The following is a description of a gene set: species: Mus musculus The chemical reactions and pathways resulting in the breakdown of a glycoprotein, a protein that contains covalently bound glycose (i.e. monosaccharide) residues; the glycose occurs most commonly as oligosaccharide or fairly small polysaccharide but occasionally as monosaccharide. Mouse Gene Set: GOBP_GLYCOPROTEIN_CATABOLIC_PROCESS, and this is the list of marker genes: Fbxo17, Ctsl, Sgsh, Stt3b, Edem1, Hgsnat, Gusb, Glb1, Hyal4, Hpse, Ngly1, Fbxo2, Nccrp1, Idua, Cst3, Mmp12, Neu4, Man1b1, Adamts12, Gpc1, Fbxo6, Hyal1, Man1a, Galns, Cela1, Manba, Naglu, Fbxo44, Gns, Fbxo27, Hexb, Edem3, Ids, Arsb, Neu2, Edem2, Hexa, Btk